The following is a description of a gene set: MicroRNA-155 (miR-155) is upregulated in primary effector CD8 T cells but is expressed at low amounts in naïve cells. Anti-viral CD8 T cell responses and viral clearance were impaired in miR-155 deficient (bic-/-) mice, and this defect was intrinsic to CD8 T cells, as adoptively transferred bic-/- CD8 T cells generated greatly reduced primary and memory responses during infection. To understand the mechanism by which miR-155 regulates CD8 T cell activation, we analyzed the gene expression profiles of naive and in vitro activated wild-type and bic-/- CD8 T cells. studied in species Homo sapiens Human Gene Set: GSE44649_NAIVE_VS_ACTIVATED_CD8_TCELL_MIR155_KO_UP from publication Gracias DT, Stelekati E, Hope JL, Boesteanu AC, Doering TA, Norton J, Mueller YM, Fraietta JA, Wherry EJ, Turner M, Katsikis PD (PMID 23603793) Genes up-regulated in CD8 T cells with MIR155 knockout: resting versus activated., and this is the list of marker genes: WDR55, SLC16A7, RPP14, SLC31A1, GSPT1, LRRC58, CRISP3, CPA3, CHORDC1, ILF3, CFI, SH2D2A, ZRSR2, TINF2, RBM17, RELL1, COX6A1, ARCN1, SNX9, TAF1D (TATA-box binding protein associated factor, RNA polymerase I subunit D), RNF4, NTMT1, NUP50, NBN (nibrin), FUBP1, RARS1, TPP1, PSENEN, IMP4, KRAS, GFI1, UTP18, SH3BP2, ENOPH1, SAG, TBK1, FBXW11, CGGBP1, HDLBP, SLC20A1, PPAN, MED1, LAPTM4B, CNOT8, PUM3 (NCBI Gene Id 9933), AHR, RASD1, DNAJB9, IFRD1, CASP4, EIF5, CLOCK, BYSL, TIMM17B, LATS2 (large tumor suppressor kinase 2), FXR1, RABGGTB, CNTN3, HNRNPA3, ETS2, LCOR, PARP2, P2RX4, CDCA4, NRGN, YTHDF1, STAT4, MRFAP1L1, ANKRD17, EPB41L4B, PRPF38A, MGAT2, USP38, SLC3A2, TRAF1, LRRC57, CCDC115, HMGN5, OSTC, RSL1D1, CAB39, PNN, PHF23, NDUFAF4, PEG10, RNF138, SH2B3, EMC6, SNRPG, FAM3C, SLC2A3, RBM4B, DDX50, METAP1, CHKA, MORF4L2 (mortality factor 4 like 2), GPD2, PGAM1, PIGR, BTG3 (BTG anti-proliferation factor 3), IRF8, TADA1, VAMP4, MARCHF6, S100PBP, FAM76B, SERPINA5, EFNB3, USF1, PRDX6, GRWD1, STK36, TUT7, TGIF2, CMTR2, HS3ST1, GAR1 (NCBI Gene Id 54433), SLBP, SLC7A5, PAIP2, TYMP, PTPN2, GNS, CLGN, ARPC3, KPNA1, PSMD12, CHD1, NAMPT, PDXK, UBA3, COP1, UTP4, TGFB3, DNPH1, NR2F1, CSTB, TOR1AIP2, SLC38A2, RETREG1, KCTD9, TIMM8A, EPO, MFSD5, CD5, EIF3A, ZZZ3 (zinc finger ZZ-type containing 3), EIF1, NOP2 (NCBI Gene Id 4839), PPP2R2B, UMPS, MFSD14A, ZFP36, SLC7A6, TUG1, SNN, TIMM9, TOM1, CHMP1B, MSX2, MFSD1, ZBTB2, TCEAL9, IRS2, SRPRA, MAPRE1, ZC3H15, GK, VPS29, FOSL1, CCL4, SLC39A6, GNAO1 (NCBI Gene Id 2775), WAC, CENPC, RRS1, PTPN6, APLP2, COPG1, WDR75, TIMM23, PER2, CRNKL1, TCERG1, SBDS, GCLC, EIF2S2, TBC1D15, PCBP1, TAB3, PPA1, CHPF, SERPINB1, NIP7, NUCB1, PCNA, DCAF13, DDX21, RBM18, UBE2N